The following is a description of a gene set: Human Gene Set: GOBP_CELLULAR_RESPONSE_TO_CORTICOSTEROID_STIMULUS Any process that results in a change in state or activity of a cell (in terms of movement, secretion, enzyme production, gene expression, etc.) as a result of a corticosteroid hormone stimulus. A corticosteroid is a steroid hormone that is produced in the adrenal cortex. Corticosteroids are involved in a wide range of physiologic systems such as stress response, immune response and regulation of inflammation, carbohydrate metabolism, protein catabolism, blood electrolyte levels, and behavior. They include glucocorticoids and mineralocorticoids. species: Homo sapiens, and this is the list of marker genes: RPS6KB1, AKR1C3, GPER1, CBX3, SMYD3, MT-ND3, CASP9, ZFP36L2, TFAP4, TBX2, ANXA1, HNRNPU, SSTR2 (NCBI Gene Id 6752), BMI1, EIF4E, ABCB1, USP8, SSTR4, ISL1, SCNN1G, SERPINF1, AXIN2, NR3C1, JAK2, FOXO3, REST, BCL2L11, ZNF764, HCN2 (hyperpolarization activated cyclic nucleotide gated potassium and sodium channel 2), GSTP1, ETNPPL, SSTR5 (somatostatin receptor 5), AQP1, SCNN1D, UBE2L3, FLT3, SGK1, NPAS4, SCNN1A, PCK2, ERRFI1, FBXO32 (F-box protein 32), CRH, STC1, MSTN, KLF9 (NCBI Gene Id 687), TGFB1, SCNN1B, PCK1, HMGCS2, DDIT4, CFLAR, ASS1, ZFP36L1, FECH, METTL21C, FAM107A, MYOD1 (myogenic differentiation 1), RAN, EDN1, ATP5F1A, ZFP36, GSK3A, SRD5A1, AIFM1